The following is a description of a gene set: The developmental process pertaining to the initial formation of the renal vesicle from condensed mesenchymal cells. The renal vesicle is the primordial structure of the nephron epithelium, and is formed by the condensation of mesenchymal cells. species: Mus musculus Mouse Gene Set: GOBP_RENAL_VESICLE_FORMATION, and this is the list of marker genes: Ctnnb1, Sall1, Wnt4, Smo, Fmn1, Sox8, Sox9, Kif26b